The following is a description of a gene set: studied in species Mus musculus Mouse Gene Set: GOBP_NEUROTRANSMITTER_GATED_ION_CHANNEL_CLUSTERING The receptor clustering process in which neurotransmitter-gated ion channels are localized to distinct domains in the cell membrane., and this is the list of marker genes: Lrrtm4, Frrs1l, Zdhhc2, Chrdl1, Shank3, Gphn, Reln, Nlgn1, Nlgn2, Shisa6, Slc7a11, Snx27, Shisa7, Dlg4, Nrxn1, Glrb, Apoe, Lhfpl4, Grip2, Htr1a, Ssh1, Slitrk3